The following is a description of a gene set: Poly(ADP-ribose) polymerase (PARP) is implicated in the maintenance of genomic integrity, given that inhibition or depletion of this enzyme increases genomic instability in cells exposed to genotoxic agents. We previously showed that immortalized fibroblasts derived from PARP(-/-) mice exhibit an unstable tetraploid population, and partial chromosomal gains and losses in PARP(-/-) mice and immortalized fibroblasts are accompanied by changes in the expression of p53, Rb, and c-Jun, as well as other proteins. A tetraploid population has also now been detected in primary fibroblasts derived from PARP(-/-) mice. Oligonucleotide microarray analysis was applied to characterize more comprehensively the differences in gene expression between asynchronously dividing primary fibroblasts derived from PARP(-/-) mice and their wild-type littermates. Of the genes monitored, 91 differentially expressed genes were identified. The loss of PARP results in down-regulation of the expression of several genes involved in regulation of cell cycle progression or mitosis, DNA replication, or chromosomal processing or assembly. PARP deficiency also up-regulates genes that encode extracellular matrix or cytoskeletal proteins that are implicated in cancer initiation or progression or in normal or premature aging. These results provide insight into the mechanism by which PARP deficiency impairs mitotic function, thereby resulting in the genomic alterations and chromosomal abnormalities as well as in altered expression of genes that may contribute to genomic instability, cancer, and aging. studied in species Mus musculus Mouse Gene Set: SIMBULAN_PARP1_TARGETS_UP Genes up-regulated in MEF cells (embryonic fibroblasts) from PARP1 knockout mice. from publication Simbulan-Rosenthal CM, Ly DH, Rosenthal DS, Konopka G, Luo R, Wang ZQ, Schultz PG, Smulson ME (PMID 11016956), and this is the list of marker genes: Cav1, Anxa3, Mdm2, Ly6a, Fgf7, Timp2, Cttn, Dcn, Fst, Mgp, App, Col8a1, Ccng1, Ccnd2, Mfap5, Igfbp6, Col4a5, S100a6, Ak1, Igfbp4, Eln, Tinagl1, Prrx2, Eef2, Serpine2, Ccn3, Cdkn1a, Cd81, Ctla2a, Ccnd1, Timp3, Ly6c1, Gpx3